The following is a description of a gene set: Mouse Gene Set: TABULA_MURIS_SENIS_BLADDER_BLADDER_CELL_AGEING from publication Tabula Muris Consortium (PMID 32669714) studied in species Mus musculus, and this is the list of marker genes: Timp3, Rps11, Gsn, Saraf, Dact1, Ftl1, Ppp1r15a, Cxcl14, H2-K1, Cd55, Rsrp1, Cfl1 (cofilin 1, non-muscle), Vasn, Eif3e, Rps17, Prnp, Pcolce2, Hbegf, Arl4c, Gem, Rps2, Ube2d3 (NCBI Gene Id 99495), Nsg1, Pnp, Rhoc, Gabra3, Rpl7, Slc38a2, Slc25a3, Ybx3, Eef1d, Hsph1, Fosl2, Rack1, Mat2a, Ubc, Ppp1r2, Rplp2, Ninj1, Zfas1, Rpl17, Dpt, Snhg1, Pabpc1, F3, Inmt, Gabarapl1, Erf, Brd2, Tgfbr2, Azin1, Impdh2, Fam107b (family with sequence similarity 107, member B), Gja1, Sparcl1, Kdm6b, Rpl24, Pdpn, Hspa5, Arl4a, Snhg12, Procr, Naca (nascent polypeptide-associated complex alpha polypeptide), Cstb, Igfbp6, Tubb2a, Myoc, Tuba1c, Rpl21, Rps6, Slc43a3, Cirbp, C3, Atf4, Il6, Stat3, Gngt2, Tomm20, Tagln2, Snu13, Tnfaip6 (NCBI Gene Id 21930), Ugcg, Eef1b2, Rps3, Slbp, Plat, Crem, Fosb, Dnaja1, Ldha, Ier3, Ahnak, Cfh, Rdh10, Eif5 (NCBI Gene Id 72643), Rps7, B2m, Map7d1, Rps15, Rplp1, Mt1, Gfpt2, Ptpn1, Hspa1a, Jpt1, Hsp90ab1, Thy1, Spsb1, Rpl32, Matn2, Raly, H2-D1, Fth1, Rps21, Nfkbia, Fau, Sprr1a, Mgst1, Hnrnpab, Tob1, Lgals3, Prss23 (serine protease 23), Rpl18, Rps14, Nop58, Rpl14, Chka, Eif3h, Cygb, Rps10, Ly6c1, Baiap2, Fbln2, Ywhaz, Rps9 (ribosomal protein S9), Rap1b, Ugdh, Ifrd1, Dlgap4, Vps37b, Mt2, Rpl29, Gadd45b, Ptgs2, Cd9, Rps3a1, Cd44, Skil, Rps24, Sdc4, Tnfrsf12a, Fosl1, Has1, 1110038B12Rik, Map1lc3b, Eif4a1, Nop56, Stmn2, Klhl21, Cxcl1, Smad7, Nfil3, Metrnl, Ndrg1, Ddx5, Mgarp, Eef1a1 (NCBI Gene Id 13627), Arpc1b, Ier5 (immediate early response 5), Pla1a, Nr4a2, Rps12, Bcl3, Pmepa1, Pcbp2, Maff, Tuba4a, Impact, Cdkn1a, Rps20, Hmox1, Wfdc2, Rpl27, Sphk1, Ndufs2, Myc, Rpl4, Rnf19b, Cnbp, Eef2, H2az1, Elf1, Plpp3, Rpl28, Tmt1a, Anxa1, Rpsa, Icam1, Fmo2, Odc1, Rpl8, Cox7a2l, Btg1, Marcksl1, Trf, Pcna, Ddit3, Pi16, Nbl1 (NBL1, DAN family BMP antagonist), Gsto1, Map2k3, Pnrc1, Hspb8 (heat shock protein 8), Tnfaip2, Eif3f, Lmna, Cltb, H2-T23, Rpl13a, Rpl27a, C4b, Hspa9, S100a10, Epb41l4aos, Hnrnph1, Map1lc3a, Rpl6, Sat1, Cdkn1c, Slc3a2, Emp1, Pfdn5, Clic4, Klf4, Use1, Rpl18a, H3f3b, Plac9, Rpl22, B4galt5, Tnfrsf1a, Il4ra, Hspa8 (NCBI Gene Id 69197), Rps25, Rps23, C1s1, Rpl5, Atp1b3, 2410006H16Rik, Txnrd1, Cfb, Ly6d, Chchd2, Nop53, Rps5, Thbs1, Dcn (decorin), Uap1, Tpt1, Rgcc, Isg15, Rpl12, Rpl13, Rpl9, Tnfaip3, Sqstm1, Prr13, Wsb1, Dpep1, Cebpb, Litaf, Ltbp4, Rplp0, Bag3, Tmsb4x, Hspb1, Fem1b, Ets2, Slc66a2, Rps13, Ptma, Bmal1, Sbds, Hsp90aa1, Rpl19, Ptbp1, Nfkb1, Ddx3x, Rpl11, Ntn1, Thbd, Gas1, Rela, Rpl35a, Rpl23, Hspa1b, Siah2, Gch1, Pim3 (proviral integration site 3), Rps4x, Eif1, Rpl10, Serpina3n, Tcp11l2, Rps16, Rpl23a, Eif5a, Mafk, Tubb4b, Xist, Etf1, Gsta3